The following is a description of a gene set: studied in species Homo sapiens Deposition of new CENPA-containing nucleosomes at the centromere Human Gene Set: REACTOME_DEPOSITION_OF_NEW_CENPA_CONTAINING_NUCLEOSOMES_AT_THE_CENTROMERE, and this is the list of marker genes: H4C9, CENPH, H4C6, H2BC9, H4C4 (NCBI Gene Id 8360), H2BC7, H2BC13, H2BC12 (H2B clustered histone 12), H4C15, H2BC11, ITGB3BP, H2BC3, H2AC20 (H2A clustered histone 20), CENPW, MIS18BP1, H2BC5, H4C13, H2AC19, H2AC18, H2AB1, RBBP7, H4C3, H2BC15, H2AZ2, CENPP, CENPT, H2AX, OIP5, H2BC6, H2AC6, H2AJ, H2BC17, CENPN, RSF1, KNL1, H2AC7, H2BC4, CENPU (centromere protein U), H4C12, CENPK, H2BC14, RUVBL1, CENPS, CENPI, H4C16, H2BC10, CENPM, H2BC8, H2BC1, H2AC8, H4C5, CENPQ, H4C1, H2BC26, H4C2, NPM1, CENPA, CENPO, SMARCA5, H4C11, H2BC12L, H4C14, H2AC4, CENPC, H4C8, MIS18A, H2AC14, CENPL, H2BC21, RBBP4, HJURP, CENPX